Given this list of marker genes Setdb2, Zic3, Epb41l5, Pitx2, Ift25, Ift172, Notch2, Cited2, Arl13b, Dll1, Mns1, Smo, Notch1, Pkd1l1, here is a description of the gene set: Mouse Gene Set: GOBP_LEFT_RIGHT_AXIS_SPECIFICATION species: Mus musculus The establishment, maintenance and elaboration of the left/right axis. The left/right axis is defined by a line that runs orthogonal to both the anterior/posterior and dorsal/ventral axes. Each side is defined from the viewpoint of the organism rather of the observer (as per anatomical axes).